The following is a description of a gene set: To develop a comprehensive catalogue of phenotypic and functional parameters of human CD4(+) T cell differentiation stages, we have performed microarray gene expression profiling on subpopulations of human thymocytes and circulating naive CD4(+) T cells, including CD3(-)CD4(+)CD8(-) intrathymic T progenitor cells, CD3(int)CD4(+)CD8(+) 'double positive' thymocytes, CD3(high)CD4(+)CD8(-) 'single positive' thymocytes, CD3(+)CD4(+)CD8(-) CD45RA(+)CD62L(+) naive T cells from cord blood and CD3(+)CD4(+)CD8(-) CD45RA(+)CD62L(+) naive T cells from adult blood. These subpopulations were sort-purified to >98% purity and their expressed RNAs were analyzed on Affymetrix Human Genome U133 arrays. Comparison of gene expression signals between these subpopulations and with early passage fetal thymic stromal cultures identify: (i) transcripts that are preferentially expressed in human CD4(+) T cell subpopulations and not in thymic stromal cells; (ii) major shifts in gene expression as progenitor T cells mature into progeny; (iii) preferential expression of transcripts at the progenitor cell stage with plausible relevance to the regulation of expansion and differentiation of these cells; and (iv) preferential expression of potential markers of recent thymic emigrants in naive-phenotype CD4(+) T cells from cord blood. Further evaluation of these findings may lead to a better definition of human thymopoiesis as well as to improved approaches to monitor and to augment the function of this important organ of T cell production. from publication Lee MS, Hanspers K, Barker CS, Korn AP, McCune JM (PMID 15210650) studied in species Homo sapiens Human Gene Set: LEE_RECENT_THYMIC_EMIGRANT Candidate genes specific for recent thymic emigrants (RTEs)., and this is the list of marker genes: LPP, AUTS2, RHOU, USP38, DSG2 (desmoglein 2), SKAP2, PET117, TIMP2, PLSCR1, GPA33, TBC1D22A-DT, JUN, PAK1, EEF1E1 (NCBI Gene Id 9521), VAV3, CACHD1, TCF4, DPH5-DT, CHML, SIKE1, GEMIN8, MTLN, LZTFL1, METTL21A, FAM241A, PRMT1, NFATC2IP, H2AC6, ABHD17B, CCNG2, TIMM8B, HERC2P9, TSPAN13, PAICS, SIDT2, IGHM, IFT80, HDAC2, RAB18, LYPLA1, NREP, PLCXD2, CDCA7, SOX4, SERF1A, AIF1 (allograft inflammatory factor 1), CENPK, MARCKS, MBTD1, CHI3L2, STK17B, KBTBD6, N4BP2L1, CDK2AP1, GATD1, KIAA0319L, MYSM1, ING3, TMOD3, TOB1, CDCA7L, PDLIM1, FUT8, NAPSB, VARS2, ATP11A, TRA2B, TNFAIP3, RHOBTB3, ANKRD55, PM20D2, TOP2A, P2RX5, CCR9, CMTR2, B3GNT2, CCR7, CYSLTR1, MTHFD2L, VPS13C, H2AC18, ANKRD10, MICAL2, VEZT, P2RY1, MTHFD1L, CRY1, DAPK1, ENSG00000284634, PSMB2, DPY19L4, PTPRC, UBASH3B, LCORL, HTR2B, MAP3K20 (mitogen-activated protein kinase kinase kinase 20), TOX, COA1, CCRL2, ISG15, RPL18A, SPRED2, FAM106A, EIF3H, KRBOX5, RGS1, LRPPRC, TMEM156, NIPSNAP3A, LYPLAL1, GTF2H3, ZC3H8, SPRY2, NIBAN3, ZBTB21, NEDD1, PDE4D, SLC2A3, PRPF19, HOOK3, SMC4, SERF2, TKT, ID2, GPR171, CSAD, ANKRD37, IGF2BP3, PDCD4, TYMS, PGM2, STMP1, ZNF271P, SENP7, MPEG1, HPGD, TOX2, RNASE6, RASA2, TENM1, YBX3, CEP57, TPRG1 (tumor protein p63 regulated 1), RNF138, TAF4B, ARL6IP6, MIF, RBM7, TRIO, ZNF776, NFKBIZ, ZCCHC9, ACBD5, ZNF542P, RPS26, H2BC12, RSAD2, XIAP, HACE1, TMEM65, SH2D1A, OXR1, CTPS1, FAM3C, CAMK4, BTBD3, QSOX2, ITM2A, ARL5A, N4BP2, ZNF738, YARS1, ZNF827, ZNF711, AEBP2, PFDN6, GPR146, CD1B, HERC2, BCOR, NINL, NR4A2, SYTL2, PCGF5, OTUD6B, PMEPA1 (NCBI Gene Id 56937), SLC25A37, TAGLN2, ABCC10, GNB4, PTGER4, THRAP3, GZMA, PAPOLA, HBG1, ERICH1, CMPK2, GATA3, HYCC1, CD93, PALM2AKAP2, PABPC1, PLAC8, CSTF2T, RPS15A, MFSD8, RNF144B, MAML3, GNAI1, MINDY2, HEG1, MPP7, IGLC2, CKS2, TNFSF10, KCTD18, DENND5A, CBL, TAF13, PXDN, ZNF677, KLHL8, SOCS3, NSD3, RPS29, FNIP2, AUH, SNORD60, DARS1, PEX13, RAI1, PCLAF, MCUR1 (mitochondrial calcium uniporter regulator 1), IFI16, H2BC5, CALHM6, BCL11A, NADK, NDUFA7